The following is a description of a gene set: Human Gene Set: HP_APLASIA_HYPOPLASIA_OF_THE_PREMAXILLA Aplasia/Hypoplasia of the premaxilla studied in species Homo sapiens Absence or underdevelopment of the premaxilla., and this is the list of marker genes: SMOC1, TGIF1, GLI2, PTCH1, SIX3